Given this list of marker genes GP1BA, GP5, GP1BB, COL1A2, COL1A1, VWF, GP9 (glycoprotein IX platelet), here is a description of the gene set: part of: Defects of platelet adhesion to exposed collagen Reactome Pathway: Enhanced binding of GP1BA variant to VWF multimer:collagen studied in species Homo sapiens